The following is a description of a gene set: Genes up-regulated in comparison of naive CD4 T cells versus natural regulatory T cell (Treg). Human Gene Set: GSE14308_NAIVE_CD4_TCELL_VS_NATURAL_TREG_UP species: Homo sapiens from publication Wei G, Wei L, Zhu J, Zang C, Hu-Li J, Yao Z, Cui K, Kanno Y, Roh TY, Watford WT, Schones DE, Peng W, Sun HW, Paul WE, O'Shea JJ, Zhao K (PMID 19144320) Multipotential naïve CD4+ T cells differentiate into distinct lineages including T helper 1 (Th1), Th2, Th17, and inducible T regulatory (iTreg) cells. The remarkable diversity of CD4+ T cells begs the question whether the observed changes reflect terminal differentiation with heritable epigenetic modifications or plasticity in T cell responses. We generated genome-wide histone H3 lysine 4 (H3K4) and lysine 27 (H3K27) trimethylation maps in naïve, Th1, Th2, Th17, iTreg, and natural (n)Treg cells. We found that although modifications of signature cytokine genes (Ifng, Il4, and Il17) partially conform to the expectation of lineage commitment, critical transcription factors such as Tbx21 exhibit a broad spectrum of epigenetic states, consistent with our demonstration of T-bet and IFN-gamma induction in nTreg cells. Our data suggest an epigenetic mechanism underlying the specificity and plasticity of effector and regulatory T cells and also provide a framework for understanding complexity of CD4+ T helper cell differentiation., and this is the list of marker genes: SOX5, SHMT1, PKN2, C12orf57, RNF180, UROC1, IFI30, BCLAF1, WASHC3, RPL14, TRMT10B, MANF, KLC1, ANKRD49, EED, ISCA2, PDLIM5, KLHL40, UBE2J2, RNF207, RECQL, VCF1, WNT5B, LSM3, CCDC115, GLE1, ENO4 (enolase 4), SLC12A1, SS18 (SS18 subunit of BAF chromatin remodeling complex), IKBKB, TCHH, DDHD1, JARID2, EMG1, CDR2, IRF7, EEPD1, XPO1, ZDHHC8, RALGPS2, FOXE3, TRIO, MMADHC, GAB3, TAF15, SCYL1, ARHGEF17, ACP5, DDX50, PNISR, MATN4, RPL7, TRIAP1, CCDC146, PCED1A, FAM110C, HNRNPA2B1, DYNLT1, STUB1, REXO4, CRTAM, BBOF1, ANKRD2, PIR, SMPD5, YTHDC1, TES, AGMAT, UBTD1, CERS6, PSMD4, VWA2, SPNS1, ATP8B3, LDHD, VWA7, FCGR1A (NCBI Gene Id 50698), UBALD2, BARX1, BRD3, TREML1, ZNF354C, ITGA2, PGAP1, BTC, ITPRIP (inositol 1,4,5-trisphosphate receptor interacting protein), ALYREF, UBXN4, SPATA31F1, C19orf53, ST8SIA1, RC3H2, PTBP3, RGCC, GPATCH4, ARL2, DDX55, MYO15B, EVI2B, CNOT6L, ZFP14, DOHH, B4GALNT2 (beta-1,4-N-acetyl-galactosaminyltransferase 2 (SID blood group)), ANKRD39, NOVA1, GPR183, IL12RB2, DZIP1, TRMT1L, MUS81, WDR74, TERB2, PLAC1, DIPK1A, FILIP1L, LAPTM5, GHRHR, LIAS, DPH7, SNRPN, RIPOR3, SMPD3, ATPSCKMT, GPR12, NELFA, AGFG2, ZHX3, SPACA4, PPARGC1B, RTN4R, GRIPAP1, PVALB, NEK3, ZNF329, HSPBAP1, GDF3, LYST, HAGH, METTL3, CLDN10, MFSD8, TNRC18, ENTPD5, SLC13A2, EARS2, DLX6, SIT1, PRL (NCBI Gene Id 5617), MAK16, MSRA, BLTP2, ID2 (NCBI Gene Id 3398), LSM7, DDX31, SLC6A17, LNPEP, CLK3, CCL4, ITK, SUCLG1, TWF1, RHO, EPN3, MAN2C1 (mannosidase alpha class 2C member 1), STK16, SCRN1, TXNDC16, PPP2R5A, ELAC1 (NCBI Gene Id 55520), PADI2, PLCXD3, STPG3, USP34, POU5F2, CRABP2, CHD2, PLCG1, EPYC, CSTF3, TSKS, ZDHHC14, GCA, SPAG6, HOXB7, CHRM3, MYCBP, C1orf74, LAIR1, SERPINH1, DUS1L, RIC8A, CHKB, ACP3, MYOZ2, RPS6KB1, ARV1, DPH1, HSBP1, CYP3A7